Given this list of marker genes RPGRIP1L, ALG5, DCDC2, FAN1, TULP3, UMOD, WDR19, here is a description of the gene set: The accumulation of collagen and related extracellular matrix (ECM) molecules in the interstitium of the kidney. The interstitium is expanded by the presence of collagen that stain blue on trichrome. Tubules are not back to back, but rather separated by fibrosis and can be atrophic. studied in species Homo sapiens Renal interstitial fibrosis Human Gene Set: HP_RENAL_INTERSTITIAL_FIBROSIS